The following is a description of a gene set: Mouse Gene Set: MIR_7242_5P Genes predicted to be targets of miRBase v22 microRNA mmu_miR_7242_5p in miRDB v6.0 with MirTarget v4 prediction scores > 80 (high confidence targets). from publication Chen Y, Wang X (PMID 31504780) studied in species Mus musculus, and this is the list of marker genes: Ate1, Kcmf1, Slc35e3, Dcstamp, Tlx3, Tal2, 4930524B15Rik, Slc1a3, Nkain3, Pcsk2, Scn1a, Galnt6, Herc4, Rcan2, Myh10, Sun1, Dna2, Zfp518b, Ss18, Spata31, Sarm1, Fbxl16, Npr3, Kif21b, Sec14l2, Ubn2, Yae1d1, Lins1, Plekha3, Magea1, AW554918, Pom121l12, Osmr, Ptprm, Slc8a1, Trim6, Slc39a8, Tmem229a, Kif5a, Ybey, Prdm1, Gimap7, Prr16, Tmem255a